The following is a description of a gene set: studied in species Homo sapiens Human Gene Set: GOBP_MATERNAL_TO_ZYGOTIC_TRANSITION_OF_GENE_EXPRESSION Any process that modulates the frequency, rate or extent of gene expression by which developmental control passes from the maternal genome to the zygotic genome., and this is the list of marker genes: PABPN1L, TPRXL, LSM14B, TPRX2, TPRX1, NR5A2